Given this list of marker genes Alkbh5, Iws1, Nsun2, Setd2, Akap8l, Thoc2, Supt6, Thoc5, Wnk1, here is a description of the gene set: Mouse Gene Set: GOBP_REGULATION_OF_MRNA_EXPORT_FROM_NUCLEUS species: Mus musculus Any process that modulates the frequency, rate or extent of the directed movement of mRNA from the nucleus to the cytoplasm.